Given this list of marker genes WNT8A, AXIN2, WNT3, CXXC4, AXIN1, SMAD6, VAX2, CAPRIN2 (NCBI Gene Id 84116, caprin family member 2), CTNNB1, MDFI, BMPR1A, SFRP1, SMAD2 (SMAD family member 2), PAX6, here is a description of the gene set: species: Homo sapiens The establishment, maintenance and elaboration of the dorsal/ventral axis. The dorsal/ventral axis is defined by a line that runs orthogonal to both the anterior/posterior and left/right axes. The dorsal end is defined by the upper or back side of an organism. The ventral end is defined by the lower or front side of an organism. Human Gene Set: GOBP_DORSAL_VENTRAL_AXIS_SPECIFICATION